Given this list of marker genes Adam6a, Adam30, Adam1a, Adam39, Adam24, Adam6b, Adam1b, Rho, Adam4, Opn4, Adam29, Hsp90ab1, Adam34, Adam25, Gm4787, Adam20, Adam26b, Adam26a, Adam21, Adam34l, here is a description of the gene set: studied in species Mus musculus Mouse Gene Set: GOCC_SPERM_HEAD_PLASMA_MEMBRANE The plasma membrane that is part of the head section of a sperm cell.